The following is a description of a gene set: Mouse Gene Set: MIR_219C_3P from publication Chen Y, Wang X (PMID 31504780) Genes predicted to be targets of miRBase v22 microRNA mmu_miR_219c_3p in miRDB v6.0 with MirTarget v4 prediction scores > 80 (high confidence targets). species: Mus musculus, and this is the list of marker genes: Dsc1, Fkrp, Rimklb, Nr2c2, Pclo, Elmo2, Neto2, Klhl4, Mix23, Nav2, Pyurf, Rapgef2, H3f5, Nck2, Ticam2, Cutc (NCBI Gene Id 66388), Calu, Ptk2, Nfkbiz, Akr1b10, Ccdc85a, Chic1 (cysteine-rich hydrophobic domain 1), Trib1, Bach1, Glrx, Ptchd4, Arl6ip6, Pabir2, Fyttd1 (NCBI Gene Id 98031), Mia2, Abl2, Mettl15, Anp32e, Il1rap, Sdcbp, Abi1, Epc1, Gpr158, Ptpn20, Hif1a, Thpo, Fhip1b, Ncoa3, Agfg1, Rbm41, Rxfp2, Lca5, Col24a1, Pus1, Cyp2c23, Vti1b, Hyls1, Zbtb34, Spen, Arl14ep, Sgpp1, Siah1a (siah E3 ubiquitin protein ligase 1A), Phf8, Fzd3, Klrd1, Katnal1, Zfp729b, Pde6d, Kcns3, Lpgat1, Cracd, Ccnc, Lypd6, H2-Eb2, Gyg1, Lrch2, Sgo2a, Natd1, Rnf2, Pacrg, Nsd3, Bicral, B4galt6, Rasgrp3, Gpr176, Ano3, Slc41a1, Rab39b, Zfhx4, Dut, Uox, Tslp, Pm20d1, Nedd9, Meikin, Fndc1 (fibronectin type III domain containing 1), Thbs4, Nsun6, Inpp5j, Mlh3, Med28, Crot, Cpne8, Ptpn12, Rab27b, Rab7